The following is a description of a gene set: studied in species Homo sapiens BACKGROUND: Chronic heart failure is characterized by left ventricular remodeling and reactivation of a fetal gene program; the underlying mechanisms are only partly understood. Here we provide evidence that cardiac microRNAs, recently discovered key regulators of gene expression, contribute to the transcriptional changes observed in heart failure. METHODS AND RESULTS: Cardiac transcriptome analyses revealed striking similarities between fetal and failing human heart tissue. Using microRNA arrays, we discovered profound alterations of microRNA expression in failing hearts. These changes closely mimicked the microRNA expression pattern observed in fetal cardiac tissue. Bioinformatic analysis demonstrated a striking concordance between regulated messenger RNA expression in heart failure and the presence of microRNA binding sites in the respective 3' untranslated regions. Messenger RNAs upregulated in the failing heart contained preferentially binding sites for downregulated microRNAs and vice versa. Mechanistically, transfection of cardiomyocytes with a set of fetal microRNAs induced cellular hypertrophy as well as changes in gene expression comparable to the failing heart. CONCLUSIONS: Our data support a novel mode of regulation for the transcriptional changes in cardiac failure. Reactivation of a fetal microRNA program substantially contributes to alterations of gene expression in the failing human heart. Genes down-regulated in samples with systolic heart failure compared to normal hearts. Human Gene Set: THUM_SYSTOLIC_HEART_FAILURE_DN from publication Thum T, Galuppo P, Wolf C, Fiedler J, Kneitz S, van Laake LW, Doevendans PA, Mummery CL, Borlak J, Haverich A, Gross C, Engelhardt S, Ertl G, Bauersachs J (PMID 17606841), and this is the list of marker genes: KANK1, CSNK1A1, LINC00881, EPCAM, STK35, RHOT1, LINC02984, MMP15, HOPX, DPY19L2P2 (NCBI Gene Id 653912), BCL11A, CD36, RNPC3, CA14, CFDP1, C8orf88, CDC42EP2, B3GALNT2, NPIPB15, LOC102724701, MAST4, NIBAN1, GGCX, TMEM165, INAVA, NKTR, TM2D1, AKAP10, ESRRG, RNU6-37P, ZFAND4, ZNF148, PPP1R10, HSP90B1, KMT5C, HCG18 (HLA complex group 18), TTC3, RAPGEF2, SMCHD1, PDZD2, AHI1, GABBR2, RPAP2, KLHDC10, ARHGEF10, TESC, ZBTB21, FTX, TMEM59, PPFIBP1, MLLT10, IP6K3, PTP4A3, SORBS2, ARSD, NEK1, PDPR2P, PPM1K, ANAPC16, AGPAT3, RORB, LMO7, RBBP6, SILC1, UQCRC2, ELL2, ADAMTS15, USH2A, BMPR1B, CEP350, CPNE4, DPF3, PLEKHA2, GKAP1, MPP3, ARHGEF7 (Rho guanine nucleotide exchange factor 7), KLHL31, RBM5, RIF1, ARMH4, SPAG9, CEP43, CUL4A, RAB18, PPM1A, H19 (H19, imprinted maternally expressed transcript), HEY2, KY, DHRS7C, MAP4K4, LAMTOR5-AS1, ZBTB48, SMAD4, PITPNB, CFLAR, KMT5B, PTEN, SNHG26, STRBP, SLC25A36, KIAA1217, ZNF579, KCNQ2, BBX, PER1, NDUFA5, PLEKHA5, AGAP12P, CHDH, GPAT3, LSAMP, UBE3C, LINC03104, CPNE5, SCAF11, PER2, POLR3E, PKD1L2, ZC3H11A, ASPH, PCBP2, DENND1B, USP54, WASL, NBEAL1, PRDM6-AS1 (PRDM6 antisense RNA 1), MAPT, SKIC8, STOX2, LSP1P5, EGLN1, MCCC2, YWHAZ, GNRH1, PER3, COX15, LINC01341, ETNPPL, DNAJC16, CDC42BPA, METAP2, SOS1, ZNF493, ZSWIM7, LINC00472, MAML1, EPN1, AKAP8L, RNU6-1016P, SQSTM1, LMLN, PPP1R9A, POLR2J4, CPEB4, CSNK2A1, CD300LG, PSD3, AK3P3, SLC38A1, SYNE1, MLEC, SPTBN1, RNF115, PDE7A, TACC1, TULP4, LCN10, ZBTB20, FAM98A, CYP4B1, SLC8A1-AS1, CLN8, HSPD1, PCDHGA8, CYCS, DLC1, NACA4P, BBIP1, SEC22C, SERHL, SUSD4, NCOR1, CAPS2, INTS6, DOCK5, PRKRA, KCNJ8, PTPN2, EP300-AS1, TALAM1, MBD4, PCDHGA10, NSG1, PPP1R2, N4BP2L2, RPL7, SGPP2, SBF2, TRIM52, C16orf46, CACNA1C, VPS13D, MUC20-OT1, SMIM8, TMEM116, PAAF1, HYCC2, PKM, TOB2, LINC00667, SEC14L5, LDB3, TANC1, LATS2, FCN3, SNHG14, VTI1A, ZNF207, THSD4, AP3D1, KLF12, UBN1, ZNF131, ZNF189, GRAMD4 (GRAM domain containing 4), PPTC7, CCDC28B, AIG1